The following is a description of a gene set: Human Gene Set: GSE2405_0H_VS_6H_A_PHAGOCYTOPHILUM_STIM_NEUTROPHIL_UP Genes up-regulated in polymorphonuclear leukocytes (6h): control versus infection by A. phagocytophilum. studied in species Homo sapiens from publication Borjesson DL, Kobayashi SD, Whitney AR, Voyich JM, Argue CM, Deleo FR (PMID 15879137) Polymorphonuclear leukocytes (PMNs) were obtained from healthy individuals in accordance with protocols approved by the Institutional Review Board for Human Subjects at the University of Minnesota and the National Institute of Allergy and Infectious Diseases. PMNs (107) were combined on ice with live S. aureus (108) or with live or heat-killed A. phagocytophilum (bacteria isolated from 5x106 infected HL60 cells for a ratio of 1 infected HL60 cell: 2 PMNs, ~ 5-20 A. phagocytophilum: PMN) in wells of a 12-well tissue culture plate (pre-coated with 20% autologous normal human serum). Unstimulated control assays received either buffer (for S. aureus comparisons) or clarified HL60 lysate (for A. phagocytophilum comparisons). Plates were centrifuged at 350 x g for 8 min at 4oC to synchronize phagocytosis and incubated at 37 deg. C in a CO2 incubator for the indicated times. At the indicated times, tissue culture medium was aspirated from the plate and PMNs were lysed directly with RLT buffer (Qiagen, Valencia, CA). Purification of PMN RNA and subsequent preparation of labeled cRNA target was performed as described in Methods. Labeling of samples, hybridization of cRNA with HU133A oligonucleotide arrays (Affymetrix, Santa Clara, CA), and scanning were performed according to standard Affymetrix protocols ( http://www.affymetrix.com/pdf/expression_manual.pdf ). Experiments were performed in triplicate, using PMNs from three healthy individuals for each treatment., and this is the list of marker genes: PRKCG, RIN1, SMYD3, SNW1, PRPS1, ZNF148, TSPAN5, USP42, RHOF, RCCD1, SOD2, SMURF1, ZNF85, SETD5, RTF1, SYNJ2BP, SETDB2, ZNRF2P1, ZMAT2, SP1, PRDX4, SUN2, CPLANE2, SERPINE1, SNORA5A, ZNF34, RHBDF1, SMC4, SUZ12P1, TSPYL5, TAX1BP1, TRUB1, ZNF106, TBC1D4, SLC15A4, SESTD1, SALL2, RPS20, SNX5 (NCBI Gene Id 27131), U2AF1, TOR1A, URB2, TMEM14C, TAFAZZIN, ZNF473, TXNDC15, PTBP1, ZNF664, PSME4, SLC3A2, SNORD63, USHBP1 (USH1 protein network component harmonin binding protein 1), TBC1D12, EMC6, SQLE, SNRPE, SNORD38A, TOMM20, TMEM69, ZNHIT6 (zinc finger HIT-type containing 6), SRI, SEC14L1, STK11IP, SACS, NEMP2, TULP1, RSBN1L, PRKAG2, STAM2, SLCO3A1, SKAP1, TLE4, TRA2A, RRAGD, RAMP3, ZBTB22, RAB3GAP1, RXRA, ZBTB39, TXNL1, SH3GL1, UROS, TLX2 (T cell leukemia homeobox 2), SNORD42A, SFT2D3, TNFRSF19, SLC4A1AP, ZNF705A, ZNF879, TBC1D24, TKT, SET, VRK2, SLC39A1, TXN, WNT5A, RPA2, SERTAD3, RIF1, STYXL1 (serine/threonine/tyrosine interacting like 1), SUGT1, PRRG3, SRSF12, TAS2R46, PRKCD, SNRPD2, PPP1R26, SYTL3, WWC3, UFD1, ZBTB43, PPP1R1C, STX8, TPST2, UNC119B (unc-119 lipid binding chaperone B), ZNF746, MRM3, TUBA1B (NCBI Gene Id 88851), SH3YL1, ZNF70, PRMT2, SLC37A3, TNFSF8 (TNF superfamily member 8), RFX5 (regulatory factor X5), SNORD54, THOC7, TSPYL4, VTRNA1-2, PPP1R9B, TTC22, SHCBP1L, SGMS1, RAP1GAP2 (NCBI Gene Id 388321, RAP1 GTPase activating protein 2), SNAP91, PSMB7, UAP1L1, TMEM9B, PROCR, RAB39B, RMND1, RAPGEFL1, ZNF621, ZRANB1, THAP9, RPS6, SMARCA4, TRMT2A, SLC39A3, RBM43, UBIAD1, RAB34, TMEM223, RNASET2, TMEM141, RNF7, ZNF714, SNORA33, UBE2I, RPS4XP21, SRCIN1, RUVBL1, SPI1, SNORA54, TRAF3, TTC23L, SENP2, XPA, TMEM14A, USP20, TCIRG1, PSMA1, SUMO3, PRDX3, SNX17, PIP4P1, TMEM237 (NCBI Gene Id 65062), PWWP2A, TRIM38 (tripartite motif containing 38), PPP4C, SLC35A1, XRCC5, PPP4R2, STAR, VIM, SCML2, ZNF672, ZNF484, VPS18, RAB5C, SPATA20, SMU1, SIRT5, ZBTB34, UBR7 (ubiquitin protein ligase E3 component n-recognin 7), ZNF781, ZNF341, XRN1, TNIP2, RXYLT1